Given this list of marker genes ATP2C2, ADAMTSL1, SPATA31F3, THRSP, FNDC7 (NCBI Gene Id 163479), CALHM1, CCDC30, FAM163B, MZF1, SLC6A14, MMP10 (NCBI Gene Id 4319), BEST1, C11orf16, TSKS, KCNV2, TPBG, AQP4, NKAIN3, RAG2, FUT7, SARS1, SPESP1, NEFM, HHIPL1, KRT1, WNT16, CAPN9, THBS2, TPH2, PRAMEF12, NHERF4, TLR9, SNCA, SVIP, GRIA1, KIRREL1, RSPO1, DUOX1, SLAMF8, GPR6, KLK7, STBD1, RBM11, USP17L5, THSD7A, TCF23, KCTD14, LMCD1, FRK, DNAJA4, SPHKAP, KEL, SIGLEC1, CYP17A1, UBIAD1 (UbiA prenyltransferase domain containing 1), COX6A2, MUC20, KRT35, PEBP1, ANKAR, SAA4, DAPK2, GRP (NCBI Gene Id 2922), WDR27, TTC9B, ADAM28, GJD2, GP9, TTC24, OGDHL, TTLL8, DMRTC1B, SP9, INSM1, SYTL5, TRIM69, MMP21, EPHA8, AKAP6, VSTM2B, MYOM1, MARCHF10, GSG1L, ITM2A, BTNL9, CDA, TMEM89, SYN2, ADGRG7, ANKRD42, GPR50, CCT8L1P, SARDH, RNFT2, SLITRK5, BMPER, KRT9, IL31RA, RCOR2, NOTO, OTOP3, MIR204, INSYN2A, SLC25A48, SOHLH1, SLCO5A1, PKD2, MN1, CERS3, LEMD1, NAA11, IGHG3, CRYM, CCNA1, PRRT3, S100A16, SEMA3E, PROK1, PLA2G2E, GUCY2D, FERMT1, SEMA3G, GHRH, here is a description of the gene set: Genes down-regulated in T reg from lypmh nodes of elderly (retired breeder) mice: wildtype versus PPARG knockout. We identified Pparg as a major orchestrator of the phenotype of adipose-tissue resident regulatory T cells (VAT Tregs). To establish the role of Pparg in shaping the VAT Tregs gene profile and cell dynamics, Tregs from lymph nodes and visceral adipose tissue of mice sufficient and deficient of Pparg expression in Tregs were double sorted for microarray analysis. studied in species Homo sapiens from publication Cipolletta D, Feuerer M, Li A, Kamei N, Lee J, Shoelson SE, Benoist C, Mathis D (PMID 22722857) Human Gene Set: GSE37532_WT_VS_PPARG_KO_LN_TREG_DN